Given this list of marker genes POLD1 (NCBI Gene Id 5424), NSMCE2, SPDYA (NCBI Gene Id 245711), MCM2, THOC6, XRCC6, PPP1CC, TERB1, ZNF827, MCM3, H4C6, APEX1, H4C14, LRWD1, ATF7, TERB2, H4C3, CDK1, WRN, TERC, DOT1L, H4C11, SMC6, ZSCAN4, H4C1, SPO11, CDK2, STN1 (STN1 subunit of CST complex), TFIP11, MAJIN, RBBP4, HDAC2, ZBTB48 (zinc finger and BTB domain containing 48), TERF1, ERCC4, MSH2, XRCC3, SSB, XRCC5, SIRT2, PINX1, RAD17, ZBTB10, H2BC3, XRCC1, H4C16, PIF1, HAT1, NAT10, MCM6, CHD4, ATR, SLF1, THOC5, UPF1, PPP1R10, ATRX, BRCA2, SP100, H4C5, TNKS, LRIF1, SIRT6, HMBOX1, H4C4, TERT, TEN1, WRNIP1, H3-3B, RECQL4, PRKDC, ORC2, ORC5, THOC7 (THO complex subunit 7), DMC1, SMCHD1, RPA4, EZH2, DHX36, TINF2, NABP2, NSMCE3, H4C12, DDB1, PURA, MCM7, NSMCE4A, H4C13, PPP1CB, PCNA, RTEL1, DNA2, SUN2, THOC1, GATAD2B, TRIOBP (TRIO and F-actin binding protein), RAD51AP1, PPP1CA, SUN1, MEN1, EZH1, RPA1, NSMCE1, MACROH2A1, NABP1, TNKS2, ORC3, CDC73, ATM, SLF2, RAD51D, H4C9, RBBP7, RPA2, SLX4, MACROH2A2, BLM, RAD51, HNRNPA2B1, CBX5, PTGES3, H2BC1, H3-4, NLRP2, PARP1, MTA2, NBN, FEN1, LIG4, RAD50, POT1, H2BW1, SMG6, H4C15, KDM1A, TERF2, PML, MCM4 (minichromosome maintenance complex component 4), TELO2, ALYREF, MCM5, TEP1, TOX4, NHP2, THOC2, H4C2, H2AC1, ORC4, CTC1, CBX1, THOC3, ORC1, DCLRE1B, KASH5 (KASH domain containing 5), CBX3, WRAP53 (NCBI Gene Id 55135), ERCC1, EID3, SETX, CHEK2, TERF2IP, SMC5, CHEK1, POLR2B, GAR1, H2AX, WDR82, RIF1, H3-3A, MRE11, RNF8, ACD, H4C8, TP53BP1, here is a description of the gene set: Human Gene Set: GOCC_CHROMOSOME_TELOMERIC_REGION The end of a linear chromosome, required for the integrity and maintenance of the end. A chromosome telomere usually includes a region of telomerase-encoded repeats the length of which rarely exceeds 20 bp each and that permits the formation of a telomeric loop (T-loop). The telomeric repeat region is usually preceded by a sub-telomeric region that is gene-poor but rich in repetitive elements. Some telomeres only consist of the latter part (for eg. D. melanogaster telomeres). species: Homo sapiens